Given this list of marker genes ITGB3, WT1, F8, H19, REST, GP9, TRIP13, POU6F2, DIS3L2, BRCA2, COL6A1 (NCBI Gene Id 1291), GPC3 (glypican 3), CLDN16, APRT, GP1BA, CD81, TRIM28, ITGA2B, GP1BB, HPRT1, here is a description of the gene set: Human Gene Set: HP_MACROSCOPIC_HEMATURIA studied in species Homo sapiens Macroscopic hematuria Hematuria that is visible upon inspection of the urine.